Given this list of marker genes WWTR1, UBE2W, CPNE3, KSR2, HTR3D, FCER2, GRIN2A, PATZ1, ARL17A (ADP ribosylation factor like GTPase 17A), GFAP, FBXO46, ITPRIPL2, SLC13A5, DLL3 (delta like canonical Notch ligand 3), CRACD, KCNC4, PPP1R9B, TMCC3, RCC2, CPNE5, COL11A2, SLC48A1 (NCBI Gene Id 55652), AGK, CSAG3, RNASEH2C, SLC25A23, CFL1, PIGL, ZNF774, AK7, P2RX2, CC2D1A, MDM4, SH3PXD2A, MAP3K13, CLIP3 (NCBI Gene Id 25999), ACSM2A (acyl-CoA synthetase medium chain family member 2A), GRM6, LINC03042, CHD6, GUCD1, MEF2D, IQGAP3, HTR3C, SRGN, B3GALT5, MINAR1, RS1, DNAJC8, RNF2, ZNF579, ZNF345, IFFO2, ITPKC, MAP1A, DNAJB4, GTDC1, GREM1, CCT8L2, SETD9, POLR3C, LCE2C, RAD51B, TRIQK, ARRB1, FABP2, MUC17, AAK1, DLK1, ZFHX2, here is a description of the gene set: Human Gene Set: MIR6812_5P studied in species Homo sapiens Genes predicted to be targets of miRBase v22 microRNA hsa-miR-6812-5p in miRDB v6.0 with MirTarget v4 prediction scores > 80 (high confidence targets). from publication Chen Y, Wang X (PMID 31504780)